The following is a description of a gene set: species: Homo sapiens Serial comparison between Th1 and Th17 tumor-specific cells cultured in vitro and ex vivo after transferred into sublethaly irradiated B6.PL mice. Th17-derived cells acquire Th1-like properties in vivo but maintain a distinct molecular profile. Human Gene Set: GSE26030_TH1_VS_TH17_DAY5_POST_POLARIZATION_DN Genes down-regulated in T helper cells 5 days post polarization: Th1 versus Th17. from publication Muranski P, Borman ZA, Kerkar SP, Klebanoff CA, Ji Y, Sanchez-Perez L, Sukumar M, Reger RN, Yu Z, Kern SJ, Roychoudhuri R, Ferreyra GA, Shen W, Durum SK, Feigenbaum L, Palmer DC, Antony PA, Chan CC, Laurence A, Danner RL, Gattinoni L, Restifo NP (PMID 22177921), and this is the list of marker genes: NME1 (NME/NM23 nucleoside diphosphate kinase 1), ABCA1, ZNF600, KIFC3, CBX5, DENND2D, NOC3L, RAB5C, PWP2, PVT1, CIPC, ARL6IP1, NIFK, ENTPD1, SLC31A1, TLE3, GABPB1, SMYD2, R3HCC1, TYROBP, ITGAL, GLYR1, BYSL, TXNRD3, IARS1 (isoleucyl-tRNA synthetase 1), ALOX5AP, URB1, SEMA4B, MDN1, CDK5RAP1, ZNF239 (zinc finger protein 239), SUCLG2, TADA2A, ACTG1, RAI1, GRIPAP1, PLBD1, DHX35, PNMT, ADAP1, ACSL1, NEDD4, PGLYRP2, GIMAP7, DNMT3L (DNA methyltransferase 3 like), UCKL1, PHF2, ACKR3, UTP4, GOLM2 (golgi membrane protein 2), DDX19B, LTA, HIVEP3, TMEM26, SMAD3, AIG1, ADAM17, NUP93, TBC1D9B, NSUN2, MTHFD1, MYH10, ATP6V0A2, VAV2, MYB, PANX1, ADGRE5, RRP15, FAM110A, RNPEP, CDV3, TK1, EZR, PPCS, ALG3, GART, CFP, DENND4B, ELL3, HS6ST1, DET1, SLC29A3, AMPD3, XXYLT1, TRAF3 (TNF receptor associated factor 3), C8orf58, SLC23A2, UBE2I, COPS7A, RAPGEF5, CAMKK1, ABCC1, CARM1, TRUB1, BID, MTHFD1L, IL12RB1, GEMIN4, PECR, NAT10 (N-acetyltransferase 10), EMID1, DPH5, COTL1, GALE, TM6SF1, POLR3E, HES1, CR2, BAMBI, EEF2K, PIP4K2A, HIVEP1, CHKA, HDDC3, INO80C, PDXK, LYST, PPA1, SEPTIN11, PLA2G7, TAF4B, MTRR, ACACA, SIPA1L2, GPR183, FGR, CD83, IRF8, GALNT11, APOA1, BTBD19 (BTB domain containing 19), SLC2A3, NOP10, SNX18, FAM167A, BCL3, SLC25A6 (solute carrier family 25 member 6), ARSB, REPS1, CDC5L, PXDC1, FKBP5, ARHGAP24, SGPL1, ATP6AP1, CHST11, IRF1, RCL1, MCOLN3, HLA-C, ABCE1, SF3A1, OVCA2, NBN, CDYL2, ABCC4, TAGAP, NFS1, LCP1, MOGS (mannosyl-oligosaccharide glucosidase), RPUSD2, CCL17, RASGEF1B, KCNQ5, HEATR1, CLEC10A (C-type lectin domain containing 10A), ALDH1B1, PFAS, IFT140, WDR5, UPB1, ABCG1, MGARP, DANCR, BCKDHB, PEAK1, FANCA, XBP1, CNOT9, FAM43A, BZW2, PER2, SHMT1, LMNB2, ADSS1, ELAVL1, UBTD2, CAPZB, DTX1, ICAM1, CAP1, ATIC, PDCD1LG2, PFKP, SPRED2, RCC1, SLC44A1